The following is a description of a gene set: species: Homo sapiens The developmental process pertaining to the initial formation of the renal vesicle from condensed mesenchymal cells. The renal vesicle is the primordial structure of the nephron epithelium, and is formed by the condensation of mesenchymal cells. Human Gene Set: GOBP_RENAL_VESICLE_FORMATION, and this is the list of marker genes: CTNNB1, KIF26B, SALL1, SMO, WNT4, SOX9, SOX8